Given this list of marker genes ALG11, here is a description of the gene set: Reactome Pathway: Defective ALG11 causes CDG-1p GDP-Man:Man(3)GlcNAc(2)-PP-Dol alpha-1,2-mannosyltransferase (ALG11) transfers the fourth and fifth mannoses (Man) to the N-glycan precursor in an alpha-1,2 orientation. These additions are the last two on the cytosolic side of the ER membrane before the N-glycan is flipped to the luminal side of the membrane. Recently discovered defects in ALG11 have been linked to congential disorder of glycosylation, type 1p (ALG11-CDG, CGD1p). The disease is a multi-system disorder characterised by under-glycosylated serum glycoproteins. Early-onset developmental retardation, dysmorphic features, hypotonia, coagulation disorders and immunodeficiency are reported features of this disorder. part of: Diseases associated with N-glycosylation of proteins species: Homo sapiens